The following is a description of a gene set: Fibrous tissue neoplasm Any neoplasm composed of fibrous tissue. species: Homo sapiens Human Gene Set: HP_FIBROUS_TISSUE_NEOPLASM, and this is the list of marker genes: APC, SDHB, SEC23B, KCNN3, PMS1, SPRED1, KRAS, NRAS, IFNG, FAM20A, MTAP, AKT1, ELMO2, PDGFB, REST (NCBI Gene Id 5978), MLH1, NF2, PLCD1, COL4A6, ATP6V1B2, CDKN1B, ANTXR2, CDKN2C, PDGFRB (platelet derived growth factor receptor beta), CTNNB1, PIK3CA, DHCR24, NOTCH3, SMO, KIT, SDHD, CREB1, PDE11A, FAS, KRT17, SDHC, PRLR, COL4A5, SPTBN1, KLLN, FASLG, CDKN2B, SMARCE1, SMARCB1 (SWI/SNF related, matrix associated, actin dependent regulator of chromatin, subfamily b, member 1), PTEN, CDC73, USF3, PRKAR1A, SOS1, CASP10, PTCH2 (patched 2), TRAF7, RSPRY1, ABCA5, FLNA, PMS2, MEN1, CDKN1A, MSH2, MSH6, TERT, IL6ST, SUFU, BAP1, HRAS, PTCH1, NF1, KCNH1, TGFBR2, LRP1, FAM20C, TSC2, TSC1, EPCAM